Given this list of marker genes Nkx2-5, Tbx3, Tbx5, Gja5 (gap junction protein, alpha 5), Gata6, Cdc42, Irx3, Dsg2, Tbx18, Mir1a-2, Shox2, Popdc2, Kcnj8, Isl1 (NCBI Gene Id 16392), Id2, Nrg1, Notch1, Bmpr1a, Mesp1, Maml1, Bves, here is a description of the gene set: The process whose specific outcome is the progression of the cardiac conduction system over time, from its formation to the mature structure. The cardiac conduction system consists of specialized cardiomyocytes that regulate the frequency of heart beat. Mouse Gene Set: GOBP_CARDIAC_CONDUCTION_SYSTEM_DEVELOPMENT studied in species Mus musculus